The following is a description of a gene set: Genes down-regulated in group D of tumors arising from overexpression of BCL2L1 and MYC in plasma cells. Multiple myeloma is an incurable plasma cell malignancy for which existing animal models are limited. We have previously shown that the targeted expression of the transgenes c-Myc and Bcl-X(L) in murine plasma cells produces malignancy that displays features of human myeloma, such as localization of tumor cells to the bone marrow and lytic bone lesions. We have isolated and characterized in vitro cultures and adoptive transfers of tumors from Bcl-xl/Myc transgenic mice. Tumors have a plasmablastic morphology and variable expression of CD138, CD45, CD38, and CD19. Spectral karyotyping analysis of metaphase chromosomes from primary tumor cell cultures shows that the Bcl-xl/Myc tumors contain a variety of chromosomal abnormalities, including trisomies, translocations, and deletions. The most frequently aberrant chromosomes are 12 and 16. Three sites for recurring translocations were also identified on chromosomes 4D, 12F, and 16C. Gene expression profiling was used to identify differences in gene expression between tumor cells and normal plasma cells (NPC) and to cluster the tumors into two groups (tumor groups C and D), with distinct gene expression profiles. Four hundred and ninety-five genes were significantly different between both tumor groups and NPCs, whereas genes were uniquely different from NPCs in tumor group C and genes were uniquely different from NPCs in tumor group D. Similar to human myeloma, the cyclin D genes are differentially dysregulated in the mouse tumor groups. These data suggest the Bcl-xl/Myc tumors are similar to a subset of plasmablastic human myelomas and provide insight into the specific genes and pathways underlying the human disease. from publication Boylan KL, Gosse MA, Staggs SE, Janz S, Grindle S, Kansas GS, Van Ness BG (PMID 17483317) Mouse Gene Set: BOYLAN_MULTIPLE_MYELOMA_D_DN studied in species Mus musculus, and this is the list of marker genes: Ctdspl, Tmem141, Prkra, Ksr1, Tdrd7, S100a6, Bcl3, Ccl9, Lifr, Cerox1, Piwil4, Pira2, Pstpip2, Ppp1r16b, Pbx2, Krt18, Il2ra, Map10 (NCBI Gene Id 74393), Cybb, Slc37a1, Flot2, Ehhadh, Chst15, Zfp975, Ipcef1, Cstf2t, S100a13, S100a1, Casp1, Sh3bp1, Arhgap21, Atp10a (NCBI Gene Id 233286), Syne3, Cd52, Marcks, Pcbp2, Casp7, Upb1, Ncf1, Ctnna1, Ahnak, Il7r, Dennd1c, Csrp1, Tifab, Pxylp1, Ppp1r3e (protein phosphatase 1, regulatory subunit 3E), Mtch1, Ddx3y, Ifi27l2a, Gsn, Arhgap26, Cgas, Abhd8, Arap2, Abtb2, Nab2, Itgam, Cd44, Slc28a2, Eva1b, Stk3, Eif2s3y, Cask, Iffo1 (intermediate filament family orphan 1), St3gal5, Maged1, Ccdc88a, Phka1, Rpgrip1 (retinitis pigmentosa GTPase regulator interacting protein 1), Anxa4, Cyth4, Atp11a, Smpd5, Hsd17b11, D17H6S56E-5, Nfkbie, Cmpk2, Crybg1, Hnrnpll, Lgals1, Ezh1, Wfdc21, Dram1